The following is a description of a gene set: Human Gene Set: BUSSLINGER_ESOPHAGEAL_QUIESCENT_BASAL_CELLS species: Homo sapiens from publication Busslinger GA, Weusten BLA, Bogte A, Begthel H, Brosens LAA, Clevers H (PMID 33691112), and this is the list of marker genes: IFITM1, RACK1, SLC1A4 (NCBI Gene Id 6509), TNC, PDLIM1, TXNIP, RPL5, MEGF6, NTRK2, GLUL, MIR205HG, ITGB4, KRT15, APP, RPLP1, ASS1, GAS5, RPS3, ZFP36L2, ALDH3A2, FOS, CD81, RPL3, LAMA5, FOSB, KRT14, CLU, DST, SERPINE2, SNHG29, SLC7A2, NFIC, IL1R2, CXCL14, PRNP (NCBI Gene Id 96713), EEF1G, CLSTN1, KRT19, SLC7A5, COL17A1, NOP53 (NCBI Gene Id 94457), SFRP1, LAMB3, RPL4, RPS6, EEF1A1, GPNMB, COL7A1, MOXD1, HSP90AB1, RPS3A, SOX6, JAG2, IFITM3, NAP1L1, EIF4B, IGFBP5, ATP1B3, JUNB, TNS1, SLC1A3, RPL10, RPL13A, SOCS3, FTH1 (NCBI Gene Id 92182), EEF2, NFIB, SYNE2, CAV1, THSD4, EIF4A2, MXRA5, DCN, RPL13, DKK3, SLC7A1, HSPA2